The following is a description of a gene set: from publication Good KL, Avery DT, Tangye SG (PMID 19124732) studied in species Homo sapiens Human Gene Set: GSE13411_PLASMA_CELL_VS_MEMORY_BCELL_UP Genes up-regulated in comparison of plasma cells versus memory B cells. Enhanced secondary Ab responses are a vital component of adaptive immunity, yet little is understood about the intrinsic and extrinsic regulators of naive and memory B cells that results in differences in their responses to Ag. Microarray analysis, together with surface and intracellular phenotyping, revealed that memory B cells have increased expression of members of the TNF receptor, SLAM, B7 and Bcl2 families, as well as the TLR-related molecule CD180 (RP105). Accordingly, memory B cells exhibited enhanced survival, proliferation and Ig secretion, as well as entered division more rapidly than naïve B cells in response to both T-dependent and T-independent stimuli. Furthermore, both IgM and isotype switched memory B cells, but not naïve B cells, co-stimulated CD4+ T cells in vitro through a mechanism dependent on their constitutive expression of CD80 and CD86. This study demonstrates that upregulation of genes involved in activation, co-stimulation and survival provides memory B cells with a unique ability to produce enhanced immune responses and contributes to the maintenance of the memory B cell pool., and this is the list of marker genes: RRBP1, PDIA4 (protein disulfide isomerase family A member 4), CLPB, AURKB, GINS3, TRIB1, MKI67, FAR2, SSR4, IGLJ3, ADGRE3, GINS2, CCR10, RFX1, SCRT1, FKBP2, BMP6, LMAN1, DTYMK, DEPP1, HMGB3, BMS1P20, CLIC2, CBX6, KDELR2, WDR76, PLAAT3, CCNB2, TOP2A, IGLV6-57, IFNAR2, H2AC17, MAT1A, CCNA2, CDC20, ELL2, ARSA, AQP3, SDC1, SSH3, CEACAM5, ZCCHC24, GSG1, TIMP2, XRCC4, H2AC16, ENSG00000291006, PRDM1, MORC1, CDKN3, SPAG5, NOC2L, LAMP5, RAB30, RAB26, ITGA6, SORT1, TRIM29, SULF1, COL3A1, SLC17A5, KIF18B, WNT5B, SDF2L1, SEC61A1, HSP90B1, TYMS, H2BC10, ELL, IGLV3-19, GTF3C5, IGKC, H2AC18, TMEM184B, MANF, PINK1, ASS1, KDELR1, SEC61B, CALU, UBE2C, PTTG1, PTTG3P, CDKN2A, NEU1, MASP1, MELK, CSTF2, CDK1, CDT1, ZNF215, COMMD4, CTH, GAGE1, H2BC6, DDR2, DNAJC1, PPP1R26, DOLPP1, H2BC8, SPC25, PSRC1, CDCA3, SMPDL3B, NEK2, AARS1, HMGB3P1, VKORC1, APOL1, RRM2, LORICRIN, RAD54L, ADTRP, H2BC7, ART4, LYPLA2, B9D1, IGFBP6, SEC14L1, CD38, AKR1C3, H2BC17, KRT6B, PRKAR2B, PXMP2, NCAPG, DARS2, TROAP, SLC35B1, GMPPB, GLDC, DEPTOR, SCAMP2, PIM2 (NCBI Gene Id 11040), CNKSR1, XBP1, H2AC13, IGKV1-5, PGM3, TXNDC15, H2BC21, TK1, TG, MITF, H3C3, CHAC1, IGF1 (insulin like growth factor 1), CDC45, CRELD2, MT1E, HDLBP, UCHL1, BCKDK, LMF1, PPP2R3A, SEL1L, CEP85, CARMIL1, AMPD1, EXO1, SERPINA2, CBARP, C3orf52, VEGFA, TNFRSF17, TERT, TPX2, DNAAF1, NT5DC2, DHRS9, MZB1, KDELR3, GANAB, EMC9, E2F2, PRMT8, OPTN, RBKS, SCAMP5, DYNC1LI2, SLAMF7, GSTM5, CYP2E1, H4C5 (NCBI Gene Id 8367), PPIB, MCHR1, H2AC14, CASQ1, TARP, CDKN1C, CTNNAL1, DNAJC3, HAX1, IL5RA, ALDH3A2, ATF6, CLPTM1, KIF20A